The following is a description of a gene set: Reactome Pathway: Formation of the polybromo-BAF (pBAF) complex part of: SWI/SNF chromatin remodelers Mammalian pBAF (polybromo-associated BAF) complex is paralogous to the RSC (remodel the structure of chromatin) complex of S. cerevisiae. Mammalian pBAF shares many of the same core subunits as cBAF, but is distinguished by the presence of ARID2 in place of ARID1A or B (Wang, Cote et al, 1996; Wang, Xue et al, 1996; Xue et al, 2000; Lemon et al, 2001; Yan et al, 2005; Mashtalir et al, 2018; Mashtalir et al, 2020; de Castro 2017; Wang et al, 2022; Yuan et al, 2022; Feoktistov et al, 2023). pBAF also contains unique subunits PHF10, BRD7 and PBRM. studied in species Homo sapiens, and this is the list of marker genes: BCL7C, ACTB, PHF10, ACTL6A, SMARCD1, BRD7, SMARCB1 (NCBI Gene Id 6598), ARID2, SMARCC2, SMARCD3, SMARCA4, SMARCA2, SMARCC1, BCL7A, BCL7B, SMARCE1, PBRM1, SMARCD2